Given this list of marker genes AMPH, RINL, DNAJC24, ACTN4, SPTBN4, KPTN, CLDN5, LANCL2, SEPTIN2, CTTNBP2, HIP1R, LSP1, MYH1, VCL, APC2, CLIC4, SPPL2B, MYO6, DNM2 (NCBI Gene Id 338330), LMOD3, PHLDB2, ACTR3, TTN, MPRIP, RAB8A, MICAL1, TPM1, SEPTIN9, MYO19, SPTB, PLS1, PRICKLE4, CALB2, KLHL14, NEURL1B, NCOA5, KALRN, ZYX, DMTN, TMC2, DLC1, RIGI, RHOQ, CAPZA3, GJB6, SPECC1, ARPC5, ARHGAP35, LMOD2, CYBA, WDR1, SH3PXD2A, SPECC1L, TMEM63B, APPL1, MYO1E, ARPC3, KEAP1, GAS2, PPP1R12A, CRK, ITSN1, NF2, CSNK1D, ACTL7B, ACTA2, SORBS1, PDLIM1, ADAM8, GABARAP, CAPZB, EPHA3, DST, SCIN, FLNA, TPM2, CAPG, CDH2, RAC2, NEB, DAPK1 (death associated protein kinase 1), CDC42BPA, SPRY2, MYO7B, CIB2, TRIP6, HSPB7, ACTR1B, PIEZO2, FYB1, WASF2, TNNI2, PEAK1, FERMT2, TTC17, FSCN2, CARMIL2, ILK, AIF1L, CARMIL1, TRPV4, AUTS2, USH1G, BIN3, EFR3B, MYO1G, MYO3B, BMF, MYLK, PDLIM5, SNCA, NDC1, ACTB, ABLIM1, LIMA1, CRYAB, SLC2A1, DIAPH2, ARPC4, FMN2, MYO1B, MYO5A, PDCD6IP, CFL2, AKAP13, GRHL3, MTPN, MYL6B (myosin light chain 6B), AMOTL2, SHROOM3, LASP1, AVIL, FKBP15, IQCG, CCDC102A, BAIAP2, TMOD1, C10orf90, FERMT3, DCTN5, ACTN1, CATIP, PTPN12, TNS3, TEK, MYO1H, RFLNA, ARPC1B, PKNOX2, SPTBN5, TRIOBP, MYH10, TNNC2, SIPA1L1, LUZP1, CTTN, MTSS1, TNNI1, FYN, FSCN1, PRKCB, SEPTIN12, DGKH, TOPBP1, MLPH, DENND2A, DHX9, DBNL, GDPD2, SYNPO2, CNN1, ARPC2, ADD2, CGN, CD2AP, SPTBN1, PAK1, ONECUT2, MYH2, SRC, WHRN, MYO1C, MYO5C, NPFFR2, ACTL9, EZR, DDR2, MYH14, ABL2, ABLIM2, VCAM1, CAPN2, SIPA1L3, MYO18B, BAG3, TM4SF19, FAM107A, CTNNA1, TNNC1, WASL, DIXDC1, ACTL8, MARCKS, SMTN, TSC1, POTEI, MYL12B, SH2B2, LLGL2, MYH16, RAB22A, ARSJ, ACTR1A, HNRNPC, RARA, NTN1, LIMCH1, POTEE, MYH4, IQGAP2, TNNT2, MYOZ1, BCAR1, MYLK3, RAI14, TAGLN3, PPP1R12C, TAOK2, FBLIM1, AIF1, ESPN (espin), IPP, CDC42EP4, HAP1, SPTBN2, STK17B, H1-0, MYL5, ACTL10, HCK, FILIP1L, CORO1C, GMFB, DBN1, FOXA3, LCP1, ROR1, GAS2L2, GYS2, PVALEF, FMN1, NCKAP1, CAPZA2, SPATA13 (spermatogenesis associated 13), MYOZ3, TMOD4, HAX1, POTEJ, MYZAP, MTSS2, ADAM17, MYH6, KLHL17, ACTRT3, CRMP1, PDLIM7, MED28, NUP85, RND1, XIRP2, YES1, MYH3, MYL7 (NCBI Gene Id 58498), MST1R, CAPZA1, STX1A, BIN1, TAF5, ANKRD23, CORIN, BIN2, DYRK1A, DOCK5, MICAL2, ARHGEF5, MSRB1, ACTG2, SNX9 (sorting nexin 9), ACTRT2, PARVB, CENPQ, NOS1AP, MYO5B, PLS3, RAC3, ANG, XIRP1, STOML2, ABRA, ACTA1, DMD, POTEKP, LPXN, NEXN, FHOD1, ADCY8, EPB41L2, ITPKA, LDB3, ACTBL2, FHDC1, CD274, RTKN, CLIC5, FILIP1, DCTN6, ARAP1, TLN2, PEAK3, MYRIP, GAS2L3, DYNLL2, ZNF74, OPHN1, VANGL2, BAIAP2L1, MARK2, VPS18, KIF9 (kinesin family member 9), CDC42BPB, COBL, RAB5A, MYH8, LPP (NCBI Gene Id 4026), WASF1, SCN8A, MYO9A, LAD1, ANLN, MYH7B, TWF2, INTS6, GFRAL, ACTC1, AFAP1, TRMT10A, KLHL20, ACTN2, SYNPO2L, GMFG, KLHL2, SH3GL1, MACF1, POF1B, DIAPH1, ACTR2, PDLIM2, FLT1, MYH7, SH3PXD2B, TPM4, ACTN3, SHROOM1, CALB1, MYO15A, DCTN3, HNRNPK (NCBI Gene Id 3190), PDXP (pyridoxal phosphatase), PPP2R3C, WAS, TNNT3, MYL1, HIP1, APBB3, BARX2, SHROOM2, RCSD1 (NCBI Gene Id 92241), PAWR, INF2, SCNN1D, NEBL, MYO10, PJVK, MYO7A, KNTC1, SPTAN1, CROCC, MYH11, CORO1B, FLOT2 (NCBI Gene Id 2319), MICALL2, NPM3, ASAP1, MAEA, ARHGAP6, PLEKHH2, ACKR2, TAX1BP3, IFIT5, MISP, PPP1R12B, MYO18A, POTEF, CALD1, CNR1, KRT19, MYO1A, LLGL1, ABL1, IQGAP1 (NCBI Gene Id 8826), CDC42EP3 (CDC42 effector protein 3), AFAP1L1, EVL (NCBI Gene Id 51466), FSCN3, ACACA, EEF1A1, STK38L, PIEZO1, MYOT, AMOT, PARVG, MYL6, PTK2, VIL1, DNAJA3, BPIFB4, RAC1, ARC, ADD1, SYNPO, DUSP22, CTTNBP2NL, TMOD3, TNNT1 (NCBI Gene Id 7138), CTNNA2, DIAPH3, MYL12A, JAM3, RHOU, LIMD2, MYO16, ATP12A, SEPTIN11, TJP1, MYL4, MYADM, RDX, MYH13, MYL3 (myosin light chain 3), GAS2L1, DSTN, ACTRT1, MPP4, PPP1R9A, MYL11, COTL1, ABI2, CORO1A, ARPC5L, RAPGEF3, GSN, GBP1, FER, CNN2, ASB2, CAP1, AXL, PDLIM4, MYO3A, TNNI3, ACTG1, PPP1R9B, NHERF1, TWF1, FCHSD1, MYO1D, KANSL2, FGR, VILL, CGNL1, CDH1, ARHGAP32, SAMD14, MYH9, MYL9, ABLIM3, CFL1, AHNAK, ACTR10, DCTN2, WIPF1, PGM5, CNN3, KNCN (NCBI Gene Id 148930), MYO1F, SHROOM4, DCTN4, SRCIN1, SORBS2, SEPTIN7, ERC1, SWAP70, FLNB, ARPC1A, DPYSL3, SPEF1, TPM3, LMOD1, CORO2B, ARHGAP21, PKD2L1, KAT2B, MYO9B, FLII, SPTA1, SHLD2, PALLD, ANXA1, RFLNB, RGS22, MYH15, DAAM1, PXN (NCBI Gene Id 80229, paxillin), SVIL, TAGLN2, ALDOA (NCBI Gene Id 226), PARVA, FLOT1, FHL3, BLOC1S6, TLNRD1, CASK, PDLIM3, VASP, ARHGAP33, PLEC, MYOZ2, TMOD2, MYL2 (NCBI Gene Id 4633), CLUAP1, here is a description of the gene set: The part of the cytoskeleton (the internal framework of a cell) composed of actin and associated proteins. Includes actin cytoskeleton-associated complexes. Human Gene Set: GOCC_ACTIN_CYTOSKELETON studied in species Homo sapiens